Given this list of marker genes Fut4, St6galnac6, St3gal6, B3galt4, St3gal3, Fut9, B3galt1, B3galt5, Fut7, Abo, B4galnt2, Fut1, St3gal4 (ST3 beta-galactoside alpha-2,3-sialyltransferase 4), B3galt2, Fut2, here is a description of the gene set: Mouse Gene Set: REACTOME_BLOOD_GROUP_SYSTEMS_BIOSYNTHESIS species: Mus musculus Blood group systems biosynthesis